Given this list of marker genes FGFR4, MALRD1, MIR33A, STARD4, STAR (NCBI Gene Id 6770), SIRT1, NR1H4, NR1D1, CYP7A1, CES1, FGF19, PROX1, here is a description of the gene set: studied in species Homo sapiens Human Gene Set: GOBP_REGULATION_OF_BILE_ACID_BIOSYNTHETIC_PROCESS Any process that modulates the frequency, rate or extent of the chemical reactions and pathways resulting in the formation of bile acids.